The following is a description of a gene set: Mouse Gene Set: GOBP_RETINA_VASCULATURE_DEVELOPMENT_IN_CAMERA_TYPE_EYE The process whose specific outcome is the progression of the vasculature of the retina over time, from its formation to the mature structure. species: Mus musculus, and this is the list of marker genes: Fzd4, Lama1, Mir23b, Hif1a, Mir218-1, Acvr2b, Arhgef15, Bmpr2, Pdgfra, Vstm4, Pdgfb, Large1, Clic4, Col4a1, Ndp, Nrp1, Acvrl1 (NCBI Gene Id 11482), Mir24-2, Rom1, Mir23a, Mir218-2, Mir27b, Tgfb1, Pdgfrb, Lrp5, Mir24-1, Mir27a, Cyp1b1, Rhoj, Slc4a7